Given this list of marker genes Epcip (exosomal polycystin 1 interacting protein), Synj2bp, Stoml2, Mfn2, Lrrk2, Agbl4, Tle6, Kat2a (K(lysine) acetyltransferase 2A), Kif1b, Trak1, Hap1, Rhot1, Wasf1 (WASP family, member 1), Uchl1, Ogt (O-linked N-acetylglucosamine (GlcNAc) transferase (UDP-N-acetylglucosamine:polypeptide-N-acetylglucosaminyl transferase)), Dynll1, Map6, Slc4a5, Agtpbp1, Mgarp, Mtm1 (X-linked myotubular myopathy gene 1), Prkn, Map1b, Pkd1, Actr10, Mef2a, Tspan4, Msto1, Mark1, Nectin2, Opa1, Armc1, Sybu, Trak2, Atcay, Ubb, Ehbp1l1, Mul1, Dnm1l, Kif5b, Bhlha15, Mfn1, Myo19, Hif1a (NCBI Gene Id 15251), Atp2a1, S2bpcox16, Zbed3, Rhot2, Hdac6, Fez1, Brat1, Hsbp1, Spast, Plin5, Kifbp, Armcx3, Cluh, Tspan9, Mapt, Nefl, here is a description of the gene set: Mouse Gene Set: GOBP_MITOCHONDRION_LOCALIZATION Any process in which a mitochondrion or mitochondria are transported to, and/or maintained in, a specific location within the cell. studied in species Mus musculus